The following is a description of a gene set: Heparan sulfate (HS) and heparin (sometimes collectively called HS-GAG) chains consist of the variably sulfated repeating disaccharide units heparan (Ido-GlcNAc) or heparosan (GlcA-GlcNAc). Heparin is exclusively made in mast cells whereas HS is made by virtually every type of cell in the body. As the chain length increases, the polysaccharides can undergo modifications such as epimerisation of glucuronic acid to iduronic acid and deacetylation and sulfation of GlcNAc to form sulfated glucosamine (Stringer & Gallagher 1997, Sasisekharan & Venkataraman 2000). Reactome Pathway: HS-GAG biosynthesis studied in species Homo sapiens part of: Heparan sulfate/heparin (HS-GAG) metabolism, and this is the list of marker genes: NDST1, HS3ST4, GPC5, GPC6, SDC2, AGRN, NDST3, HS3ST3A1, NDST4, EXT1, HS6ST2 (NCBI Gene Id 90161), EXTL2, EXT2, GLCE, HS3ST5, NDST2, SDC1 (NCBI Gene Id 6382), HS3ST3B1, HS2ST1, GPC3, HS3ST2, SDC3, HS3ST1, GPC2, HS6ST3, SDC4, HSPG2, SLC35D2, GPC1, EXTL3, HS3ST6, HS6ST1, GPC4